The following is a description of a gene set: from publication Chen Y, Wang X (PMID 31504780) Human Gene Set: MIR548AL studied in species Homo sapiens Genes predicted to be targets of miRBase v22 microRNA hsa-miR-548al in miRDB v6.0 with MirTarget v4 prediction scores > 80 (high confidence targets)., and this is the list of marker genes: RNF43, EIF4G2 (NCBI Gene Id 1982), PPP3CA, EIF4E3, ZNF292, EPHA4, NSD2, GPATCH2L, FEM1A, MIER3, CENPBD1P, ATRNL1